The following is a description of a gene set: An abnormality of the intestinal rotation and fixation that normally occurs during the development of the gut. This can lead to volvulus, or twisting of the intestine that causes obstruction and necrosis. Human Gene Set: HP_INTESTINAL_MALROTATION Intestinal malrotation species: Homo sapiens, and this is the list of marker genes: DNAAF4, CFAP74 (NCBI Gene Id 93196), DNAL1, CFAP221, TMEM216, DNAH5 (dynein axonemal heavy chain 5), IPO8, CFAP300, WASHC5, KAT6B, IRF1, DNAAF11, HMGA2, ABL1, KDM6A, DNAAF6, HNRNPU, HIRA, DPYSL5, ALG12 (NCBI Gene Id 79087), SPEF2, ZMYND10, DNAH11, PIGN, CCDC39, GATA6, NEK1, TMEM94, ASXL3, DNAI1, RSPH3, DNAAF3, LRP2, FREM2, EP300, RREB1 (NCBI Gene Id 6239), NOTCH2, MED12, FOXF1, CFAP298, LETM1, NODAL (NCBI Gene Id 8114), ODAD2, MCIDAS, CREBBP, SMO, NEK10, ACTG2, EXT2, JMJD1C, DSE, RSPH9, UBE3B, FGFR2, GP1BB, PI4KA, CCDC22, LONP1, SMC3, SPAG1, MYLK, CPLX1, BRD4, SMC1A, DNAAF2, ACTA2, SALL4, HDAC8, MKS1, FBN2, NPHP3, ROBO1, NSD2, SIX1, DYNC2H1, ODAD4, FLNB, LEMD3, PORCN, COMT, ODAD3, GAS2L2 (growth arrest specific 2 like 2), SMAD2, LMOD1 (NCBI Gene Id 25802), CENPF, FARSB, DNAJB13, GPC3 (glypican 3), ARID1B (AT-rich interaction domain 1B), FLNA, ISL1, RPGR, ARVCF, CAMK2A, DHODH, IFT43, ASXL1, RAD21, ERBB3, CLMP, CHRM3, SPINT2, TAF6, CFC1, LRRC56, DNAH1, OFD1, CFAP45, RSPH1, TFAP2A (transcription factor AP-2 alpha), DHCR7, BCOR, GPC4, MMP21, FLI1, RFX6, DNAI2, ZPR1, MYH11, RSPH4A, CCNO, DRC1, TTC7A, CHST14, ODAD1, EYA1, RARB, STK36, VPS35L, UFD1, KMT2D, CTBP1, NME5, CCDC40, AMER1, DHCR24, WNT4, DNAAF1, TP63, TTC12, NME8, KAT6A, SETD5, ZFPM2, SLC12A2, NIPBL, DNAH9, HYDIN, MYRF, FGFRL1, SEC24C, DNAAF5, FOXJ1, TBX1